Given this list of marker genes Sfxn1, Slc38a2, Slc38a5, Slc1a4, Sfxn3, Slc1a5, here is a description of the gene set: Mouse Gene Set: GOMF_L_SERINE_TRANSMEMBRANE_TRANSPORTER_ACTIVITY species: Mus musculus Enables the transfer of L-serine from one side of a membrane to the other. L-serine is the L-enantiomer of 2-amino-3-hydroxypropanoic acid.